The following is a description of a gene set: Mouse Gene Set: REACTOME_SYNTHESIS_OF_DOLICHYL_PHOSPHATE Synthesis of dolichyl-phosphate studied in species Mus musculus, and this is the list of marker genes: Dhdds, Mvd (NCBI Gene Id 97454), Srd5a3, Dolk, Nus1 (NUS1 dehydrodolichyl diphosphate synthase subunit), Dolpp1